The following is a description of a gene set: Human Gene Set: GOMF_GLUTAMATE_BINDING studied in species Homo sapiens Binding to glutamate, the anion of 2-aminopentanedioic acid., and this is the list of marker genes: CPS1, GRM7, GRIN2B, GCLC, GRIN1, GRIN2D, SLC1A3